Given this list of marker genes MELK, SMG8, NCAPG, SLC52A2, KDM3A, WDR12, ELOC (elongin C), IPO7, MARCKS, DKC1, CYB5B, EIF2S1, MAD2L1, MAPRE1, SNRPD2, NTAQ1, AGA, BUB1, UBR5, TPD52L2, CEP55, G6PD, AIMP1, ENO1, CCT2, CKLF, JPT1, GTF3C3, PRKAR1A, PFN2 (profilin 2), SNRPA1, PIGF, ARPP19, CASC3, PRMT5, PTP4A2, STMN1, FXR1, ENOPH1, COPS5, ARPC4, C5orf22, MPZL2, GMFB, DUSP3, LRRC59, NARS1, PTBP2, KLC1 (NCBI Gene Id 3831), CSDE1, BRD7, GOLT1B, HMMR, TOPBP1, ZWILCH, RPL8, GPN1, TAF2, NME2, CANT1, LANCL1, MED1, TRIM31, NCAPD2, RPRD1A, EBNA1BP2, EMC1, MPV17, SUB1, SRI, MRTO4, MRPL42, TPD52, PSME3, CDC6, CCNA2, MED24, WASHC5, SLC7A1, SAP30BP, GNB1, WDR45B, TXN, TSN, UGCG, PSMC6, TBL1XR1, ASAP1, EML4, CSNK1D, FTH1, SMAD2, NME1, UTP18, CCT5, RAD21, NLE1 (NCBI Gene Id 54475), SRM, NUP155 (NCBI Gene Id 9631), POLR2K, PSMD14, SEC61G, NPEPPS, SNX7, CBX3, PGD, FANCI, EZH2, PGK1, COIL, H2BC21, ANP32E (acidic nuclear phosphoprotein 32 family member E), DR1, CENPM, TMX1, TTK, VMP1, KIF2C, DNAJC10, GNL3 (G protein nucleolar 3), ADSL, ACACA, GLA, PLEKHF2, USP14, PHLDA2, NDC1, CCDC86, DHX15, NUP37, PLOD2, SMC1A, NOL11, LRP12, PUS7, PPP1CC (protein phosphatase 1 catalytic subunit gamma), TRIP13, CCT4, TPRKB, NDC80, ITGB1BP1, PRIM1, RAD51AP1, PHB1, ACTL6A, EIF4A3, LPCAT1, PDCD2, XPO1, BOP1, TIPIN, TMEM185B, TDG, USP3, TACC3, SLC38A6, PSMD11, RFC3, RIT1, ATIC, NRAS (NCBI Gene Id 4893), SLC16A3, PAPOLA, NDRG1, PAK1IP1, IPO5 (NCBI Gene Id 3843), RBM28, CLIC1, HNRNPR (NCBI Gene Id 10236, heterogeneous nuclear ribonucleoprotein R), NSF, EIF3H, FAM50A, PSMC4, PWP1, UBE2V2, EIF3B (NCBI Gene Id 8662), RBBP4, FNBP1L, KIF2A, PTGES3 (prostaglandin E synthase 3), NUP107, HGS, KIF1B, NGRN (NCBI Gene Id 51335), PPP2R3C, TGIF1, MMD, HJURP (NCBI Gene Id 55355), UCK2, KPNB1, here is a description of the gene set: Human Gene Set: BOYAULT_LIVER_CANCER_SUBCLASS_G3_UP from publication Boyault S, Rickman DS, de Reyniès A, Balabaud C, Rebouissou S, Jeannot E, Hérault A, Saric J, Belghiti J, Franco D, Bioulac-Sage P, Laurent-Puig P, Zucman-Rossi J (PMID 17187432) Hepatocellular carcinomas (HCCs) are a heterogeneous group of tumors that differ in risk factors and genetic alterations. We further investigated transcriptome-genotype-phenotype correlations in HCC. Global transcriptome analyses were performed on 57 HCCs and 3 hepatocellular adenomas and validated by quantitative RT-PCR using 63 additional HCCs. We determined loss of heterozygosity, gene mutations, promoter methylation of CDH1 and CDKN2A, and HBV DNA copy number for each tumor. Unsupervised transcriptome analysis identified 6 robust subgroups of HCC (G1-G6) associated with clinical and genetic characteristics. G1 tumors were associated with low copy number of HBV and overexpression of genes expressed in fetal liver and controlled by parental imprinting. G2 included HCCs infected with a high copy number of HBV and mutations in PIK3CA and TP53. In these first groups, we detected specific activation of the AKT pathway. G3 tumors were typified by mutation of TP53 and overexpression of genes controlling the cell cycle. G4 was a heterogeneous subgroup of tumors including TCF1-mutated hepatocellular adenomas and carcinomas. G5 and G6 were strongly related to beta-catenin mutations that lead to Wnt pathway activation; in particular, G6 tumors were characterized by satellite nodules, higher activation of the Wnt pathway, and E-cadherin underexpression. CONCLUSION: These results have furthered our understanding of the genetic diversity of human HCC and have provided specific identifiers for classifying tumors. In addition, our classification has potential therapeutic implications because 50% of the tumors were related to WNT or AKT pathway activation, which potentially could be targeted by specific inhibiting therapies. studied in species Homo sapiens Up-regulated genes in hepatocellular carcinoma (HCC) subclass G3, defined by unsupervised clustering.